Given this list of marker genes RAB7A, UBLCP1, LIPA, PLTP, NUP205, NUP50, FAM209A, CASR, PKP2, DIRAS2, SCAMP5, METTL24, CADPS, MGAT4EP, PROX2, KRT17, B3GNT5, IZUMO2, ZNF655, GMCL1, SERPINA12, SUPT3H, DKK2, CHAD, ANXA2, TRIM37, DAB2, BLTP2, C3orf62, AGBL4, CCDC77, CAPN2, PLXDC1, RHO, MFGE8, RGL1, ZC3H12C, ZSCAN2, COX10, POLK, TIAM1, CMAS, MRTFB, TRPV2, ANGPTL2, SORCS3-AS1, SSPOP, WASHC5, PWWP3B, STT3B, ABHD16B, TACC1, PAX9, KRAS, MICAL1, SPNS1, COBL, ESYT1, CDK20, ABCF2, ADAM33, KCNK10 (potassium two pore domain channel subfamily K member 10), COL6A3, IDO2, ERGIC1, PRR5L, ITGA7, TRPS1, GALC, SLC36A1, TRAPPC8, STAM2, FANCD2OS, PI15, CBR3, PARD3B, ARPIN, ZNF143, MMP19, CD93, WFDC2 (NCBI Gene Id 128489), CSE1L (chromosome segregation 1 like), COL18A1, CPED1, NELL2, EYA4, NHSL2, COL27A1, CAMLG, SAMD8, LRRC72, RIC1, ZBTB3, C6orf62, VIPAS39, TNS3, RBM15B, UBR3, GSDME, ARFGEF2, CCNYL1, MSS51, MGAT1, KHDRBS3, RTKN, SNAP29, FBXO33, SPMIP7, CLOCK, CADM1, IRX5, WIPF1, ARHGAP25, HGS, ADRA1A, TRIM7, SLC7A11, GCFC2 (GC-rich sequence DNA-binding factor 2), ABCC6, SUV39H2, COL4A4, SPRY3 (NCBI Gene Id 253479), SULT1A1, SLC37A2, ADCY8, VGLL1, CCDC71L, SPP2, NSUN5, SYNJ1, CLUH, EXTL2, HTR2C, PUS1, TPTE, AP2A1, TESK2, SLC9A1 (NCBI Gene Id 6548), PRKAR2A, GRAMD2B (GRAM domain containing 2B), TTC22 (tetratricopeptide repeat domain 22), MVP, SULF1, ACOT2, PKP4, NOBOX (NCBI Gene Id 402714), CD74, RHOB, KLF6, CPA2, LRIG1, VPS37B, WASF1, SLC15A4, ST14 (NCBI Gene Id 6768), ATP6AP1, CAPN15, MSR1, NHERF4 (NCBI Gene Id 79849), TTLL7, SELENOP, SFMBT1 (NCBI Gene Id 51460), VPS36, NSDHL, NCCRP1, TMEM130 (NCBI Gene Id 222865), EMP3, SPATA6, NALCN, ARL4C, MYO3B, IL1RL1, CCDC54, TANC2, CD164L2 (CD164 molecule like 2, NCBI Gene Id 388611), SIX5, POSTN, SRXN1, SUDS3, KRT26, FAM3D, ALDH1L1, NPHP1, MAGEA11, NAB1, FDPS, RMND5B, ANKH, TMEM41B, GOLT1B, RAB14, RGS13, ZNF14, ZNF264, TENM4, FBXO30, ALDOB, HSFY2, CNR2, LPIN2, here is a description of the gene set: Genes up-regulated in cortical thymic epithelial cells (cTEC) versus thymic dendritic cells. Gene expression in different thymic stromal cells and subsets thereof was analyzed in 6-12 week old wild type (C57BL/6) and Aire knock-out (mixed background) mice. Thymic stromal cells were purified by sequential enzymatic digestion (collagenase, collagenase/dispase and trypsin) followed by gradient centrifugation and FACS sorting. Sort criteria were as follows: dendritic cells (CD11c+, F4/80 -), macrophages (F4/80+, CD11c-), cTECs (CD45–/lo, CDR1/Ly51+, Ep-CAM+) and mTECs (CD45–/lo, CDR1/Ly51–, Ep-CAM+). mTECs of wild-type and Aire knock-out mice were further subdivided according to CD80 expression levels. For microarray analysis total RNA from thymic stromal cell samples of two independent experiments was pre-amplified and biotinylated by two rounds of cDNA synthesis and in vitro transcription. Fluorescence readings were evaluated by using Microarray Suite 5.0 software. Human Gene Set: GSE2585_CTEC_VS_THYMIC_DC_UP from publication Derbinski J, Gäbler J, Brors B, Tierling S, Jonnakuty S, Hergenhahn M, Peltonen L, Walter J, Kyewski B (PMID 15983066) species: Homo sapiens